Given this list of marker genes Hspa1b, Hspa1a, Mx1, Ccl5, Dusp1 (NCBI Gene Id 98098), H2ac25, Rgs1, Mt1, Klf2, here is a description of the gene set: Genes negatively differentially expressed in cell type: MigDC (migratory dendritic cell) upon treatment with cytokine: IL-2 in mouse lymph nodes in vivo. from publication Cui A, Huang T, Li S, Ma A, Pérez JL, Sander C, Keskin DB, Wu CJ, Fraenkel E, Hacohen N (PMID 38057668) Cytokines mediate cell-cell communication in the immune system and represent important therapeutic targets. A myriad of studies have highlighted their central role in immune function, yet we lack a global view of the cellular responses of each immune cell type to each cytokine. To address this gap, the authors created the Immune Dictionary, a compendium of single-cell transcriptomic profiles of more than 17 immune cell types in response to each of 86 cytokines (>1,400 cytokine-cell type combinations) in mouse lymph nodes in vivo. A cytokine-centric view of the dictionary revealed that most cytokines induce highly cell-type-specific responses. For example, the inflammatory cytokine interleukin-1β induces distinct gene programmes in almost every cell type. A cell-type-centric view of the dictionary identified more than 66 cytokine-driven cellular polarization states across immune cell types, including previously uncharacterized states such as an interleukin-18-induced polyfunctional natural killer cell state. studied in species Mus musculus Mouse Gene Set: CUI_MIGDC_IL2_RESPONSE_DN